Given this list of marker genes NOTCH1, NOTCH4, POGLUT1, NOTCH3, POFUT1, NOTCH2, here is a description of the gene set: Pre-NOTCH Processing in the Endoplasmic Reticulum species: Homo sapiens Human Gene Set: REACTOME_PRE_NOTCH_PROCESSING_IN_THE_ENDOPLASMIC_RETICULUM